The following is a description of a gene set: species: Homo sapiens Enterohepatic circulation of bile acids Human Gene Set: WP_ENTEROHEPATIC_CIRCULATION_OF_BILE_ACIDS, and this is the list of marker genes: ABCB1, SLCO1B1, FABP6, SLCO1B3, ABCC4, ABCC2, SLC10A2, ABCB11, SLC51A, SLC51B, ABCC3, SLC10A1